Given this list of marker genes Il1b, Pcbp2, Eif2ak4, Rnf26, Il15, Foxp3, Mul1, Cgas, Sin3a, Nt5c2, Stat1, Selenok, Rigi, Ilrun, Ercc6, Creb3, Cd37, Elmod2, Aim2, Trim38, Irgm2, Dhx9, Itch, Ifna1, Mmp12, Traf3ip1, Il12rb1, Rnf216, Gbp4, Mavs, Igtp, Sting1, Traf3, Atg12, Pml (promyelocytic leukemia), Spn, Pycard, Zdhhc1, Trim6, Htra1, Dtx3l, Fgl2, Rnf26rt, Il23r, C1qbp, Ppm1b, Treml4, Pqbp1, Ptpn22, Ifnlr1, Il27, Tarbp2, Irgm1 (NCBI Gene Id 15944), Hsp90aa1, Ifng, Il4, Il12b, Sertad3, Zc3hav1, Zdhhc11, Parp9, Tspan32, Il23a, Traf3ip2, Apobec3, Ccl5, Zc3h12a, Trim44, Zmpste24, Usp17le, Atg5, Tomm70a, here is a description of the gene set: Any process that modulates the frequency, rate or extent of the antiviral response of a cell or organism. studied in species Mus musculus Mouse Gene Set: GOBP_REGULATION_OF_DEFENSE_RESPONSE_TO_VIRUS